The following is a description of a gene set: Genes predicted to be targets of miRBase v22 microRNA hsa-miR-4266 in miRDB v6.0 with MirTarget v4 prediction scores > 80 (high confidence targets). Human Gene Set: MIR4266 from publication Chen Y, Wang X (PMID 31504780) studied in species Homo sapiens, and this is the list of marker genes: ZNF655, GPLD1, MMAA, ADAMTS15, MAPT, ZCCHC17, KPNA7, OGT, WNK3, LGR4, SNTB2, RAD23A, MYBPC1, PHYKPL, SHISA9, ATP11C, F2R, TRIM39, IKZF3, LHX9, AQP10, KCTD16, GIGYF2, ZNF76, NDUFS4, SPN, JAK3, LMLN, RAB23, CDC42EP3, EXPH5, CUEDC1, GNL3L, ZBTB39, TSFM, CASP14, ARIH1, PCNX1, SCN2B, IL17RA, FAM219A, HEATR5B, DTNB, ASPRV1, TMTC1, RBBP5, PHYHIPL, ZFHX4, TMEM255A, SRGAP2, KRAS, RAPH1, CASK, DPP8, COL24A1, ACVR1B, UQCRQ, WNT1, CCL28 (NCBI Gene Id 56477), RIOX2, DNAAF9, CLYBL, PTGES3, MRPL43, SYNPO2, R3HDM1, GATM, RNF38, LURAP1L, SH3PXD2B, TICRR, NADK2, RAB2B, ZNF365, KRT31, PLEKHM3, KSR1, FBXW11, ACSL5, GTSF1, RLIG1, OSBP, TREML1, SETD3 (SET domain containing 3, actin N3(tau)-histidine methyltransferase), ELK4